Given this list of marker genes VAMP7, TRPC6P1, WASH6P, DDX11L16, CTBP2P1, ELOCP24, WASIR1, PARP4P1, IL9R, DPH3P2, CCNQP2, AMD1P2, here is a description of the gene set: Human Gene Set: chrYq12 studied in species Homo sapiens